The following is a description of a gene set: Mouse Gene Set: MIR_6372 from publication Chen Y, Wang X (PMID 31504780) Genes predicted to be targets of miRBase v22 microRNA mmu_miR_6372 in miRDB v6.0 with MirTarget v4 prediction scores > 80 (high confidence targets). species: Mus musculus, and this is the list of marker genes: Ppp2ca, Mideas, Clcf1, Srsf3, Rps6ka3 (NCBI Gene Id 331563), Ncam2, Pam, Rhog, Mllt1, Gpatch1, Nktr, Rbfox2, Ankra2, Myo15a, Vash1, Spats2, Rad51ap2, Dr1, Camsap1, Zfp93, Zdhhc3, Ccser2, Abcc4, Tardbp (NCBI Gene Id 97174), U2af1, Cyp2c37, Plppr1, Nek9, Elk3, Rora, Arv1, Sema4b, Epha4, Rlig1, Fgf1, Cd44, Arel1, Slc18a2, Zfp248, Nrg3, Hnrnpd, Aif1l, Ddb1, Wars2, Mecp2, Ugp2, Osbpl9, Cndp1 (NCBI Gene Id 338403), Ro60, Lce6a, Lrit1 (NCBI Gene Id 239037), Xxylt1, Pard6g, Aph1a (NCBI Gene Id 76226), Pias2, Tbr1, Chd6, Gabrr2, Filip1l, Cxcl12, Rarb, Cmpk2, Fam168b, Lin7c, Ywhaq, F830045P16Rik, Arid4b, Litaf, Acvr2b